Given this list of marker genes NAALADL2, FAM8A1, NEXN, CHST7, MMP12, USP6, RPS6KA3, EFR3B, GTF2A1, NAP1L4, MIX23, HSPA4, ZFYVE9 (zinc finger FYVE-type containing 9), CUL3, FAM24A, EGLN1, HNRNPR, C1GALT1C1L, SELENOP, GPALPP1, RHEB, TOR1A (torsin family 1 member A), RPIA, WNT16, TAOK1, PRUNE1, SLCO2A1, ITGA9, ZRANB3, DMXL1, SPARC, KCNH5, TRPC4AP, NDNF, MEI4, APPL1, KCTD13, TRAPPC14, INTS13, RORA, SHTN1, PDLIM5, OSTM1, NINL, EXOC6B, ABHD18, LANCL3, BMP2, GABARAPL2, NDUFB4, ADCY5, CFAP65, PGAP1, STOX1 (storkhead box 1), KAT2B, DISC1, CREBZF, DNAJB14, GNPDA1, SYCP1, MYEF2, KGD4 (alpha-ketoglutarate dehydrogenase subunit 4), ANKRD17, MSR1 (NCBI Gene Id 4481), TMEM220, SLC19A2, SPDL1, MTMR10 (myotubularin related protein 10), PKIB, TRAPPC13 (NCBI Gene Id 80006), IL34 (interleukin 34), EXT1, NR2C2, SMAD4, PFN2, IVNS1ABP, BPNT1, ZNF585A, IFNA21, CIART, HOXD8, LEMD3, TMOD3, CAMK2G, ZNF711, UBE2N (NCBI Gene Id 7334), FUBP3, C3orf38, PLSCR1, USP32, GALNT13 (NCBI Gene Id 114805), PRR15, EXOSC9, NEXMIF, CCK, CLOCK, RETREG1, OSR1, PAFAH1B1, CREB1, FGD4, ESF1, CA11, MGAT4A, EPHA5, MKX, GLIS3, CPS1 (carbamoyl-phosphate synthase 1), SETBP1, HSD17B4, PELI2, CYP4X1, CPEB2, FAM168A, SPARCL1, FBXL12, MPDU1, HCCS, DPY19L1, ZNF184, METTL15, ARL5A, MDN1, GNB4, NEK1, FAM161A, PPP1R3D, MTERF2, ARFGEF2, MYRIP, SORCS3, CFHR2 (NCBI Gene Id 82725), DPP8, TRIM33, CALR, GCC2, ROBO2, MYLIP, EIF2AK2, PROS1, RXFP1, POLR3G, GLIPR1L2, here is a description of the gene set: studied in species Homo sapiens from publication Chen Y, Wang X (PMID 31504780) Genes predicted to be targets of miRBase v22 microRNA hsa-miR-633 in miRDB v6.0 with MirTarget v4 prediction scores > 80 (high confidence targets). Human Gene Set: MIR633